The following is a description of a gene set: The actin filament-based process in which cytoplasmic actin filaments slide past one another resulting in contraction of all or part of the cell body. Mouse Gene Set: GOBP_ACTIN_MEDIATED_CELL_CONTRACTION species: Mus musculus, and this is the list of marker genes: Rangrf, Myl6b, Camk2d, Slc9a1, Atp1a1, Pik3ca, Kcne1, Pdpn, Cav3, Cav1, Luzp1, Bin1, Tnnt2, 3425401B19Rik, Kcnd3, Sri, Jup, Gata4 (GATA binding protein 4), Cacna1d, Scn1a, Kcnh2, Cacnb2, Dlg1, Myo9b, Sumo1, Akap9, Abcc9, Nos1, Scn2b, Sgcd, Casq2, Kcnj8, Rnf207, Kcne5, Frmd6, Dsg2, Gpd1l, Shtn1, Dsc2, Atp2a2, Pard3, Dsp, Kcna5, Uty, Nup155, Scn1b, Ptger3, Atp1a2, Mylk2, Nedd4l, Gja5, Atp2a1, Limch1, Kcne2, Pln, Myh7b, Trpm4, Actc1, Scn4b, Myh9, Parva, Tnni3, Stc1, Kcnq1, Myh8, Rock1, Myh7, Hcn4, Emp2, Tpm1, Fgf13, Kcnj2, Pkp2, Adcy10, Cacna1h, Zeb2, Ctnna3, Myh6 (myosin, heavy polypeptide 6, cardiac muscle, alpha), Dbn1, Cacna1c, Kcne3, Ryr2, Kcnj5, Flna, Pde4d, Akap6, Kcnn2, Acta2, Ank2, Cacna2d1, Kcne4, Adrb1, Adora1, Tnnc1, Vil1, Fxyd1, Epb41l5, Myl6, Qki, Gsn, Ccdc88c (NCBI Gene Id 68339), Scn5a, Scn3b, Strit1, Snta1, Epdr1